The following is a description of a gene set: Differentiation induction is an effective therapy for acute promyelocytic leukemia (APL), which dramatically responds to all-trans-retinoic acid (ATRA). Recent studies have indicated that combinatorial use of retinoid and nonretinoid compounds, such as histone deacetylase inhibitors, arsenics, and PKA agonists, has higher therapeutic value in this disease and potentially in other malignancies. In a screen of 370 compounds, we identified benzodithiophene analogues as potent enhancers of ATRA-induced APL cell differentiation. These effects were not associated with changes in global histone acetylation and, for the most potent compounds, were exerted at very low nanomolar concentrations, and were paralleled by enhancement of some, but not all, ATRA-modulated gene expressions. Investigating the mechanism underlying the effects of these drugs on ATRA-induced APL cell differentiation, we have shown that benzodithiophenes enhance ATRA-mediated dissociation and association of corepressor N-CoR and coactivator p300 acetyltransferase, respectively, with retinoic acid receptor (RAR) alpha proteins. These data suggest that benzodithiophenes act at the level of receptor activation, possibly by affecting posttranslational modification of the receptor (and/or coregulators), thus leading to an enhancement in ATRA-mediated effects on gene expression and APL cell differentiation. Given the specificities of these low benzodithiophene concentrations for PML-RARalpha and RARalpha, these drugs may be useful for combinatorial differentiation therapy of APL and possibly other acute myelogenous leukemia subtypes in which the overall ATRA signaling is suppressed. Genes up-regulated synergistically in NB4 cells (acute promyelocytic leukemia, APL) by tretinoin and NSC682994. Human Gene Set: XU_RESPONSE_TO_TRETINOIN_AND_NSC682994_UP from publication Xu K, Guidez F, Glasow A, Chung D, Petrie K, Stegmaier K, Wang KK, Zhang J, Jing Y, Zelent A, Waxman S (PMID 16140955) species: Homo sapiens, and this is the list of marker genes: GSTP1, CXCL8, ANXA1, CD53, STAT1, LAMP2, MYH9, TNFSF10, ITGA6, HDAC1, IFITM1, NMI, STK10, ICAM3, BIRC2